Given this list of marker genes Pnp, Urad, Nt5c1a, Xdh, Ada, Urah, Uox, here is a description of the gene set: species: Mus musculus Mouse Gene Set: GOBP_DAMP_CATABOLIC_PROCESS The chemical reactions and pathways resulting in the breakdown of dAMP, deoxyadenosine monophosphate (2'-deoxyadenosine 5'-phosphate).